Given this list of marker genes MAPK3, SP100, FCGR1BP, NUP42, FANCF, IKBKB, FAAP24, HSPA1B, TUBA1B, TUBB2B, PDE12, EIF4E2, TRIM21, SOCS3, FANCM, ILF3, EIF4A2, NUP155, TRIM29, HLA-DQA1, NCK1, GBP4, TUBA1C, JAK1, EIF4G1, MAVS, SPHK1, HLA-DQB2, FNTA, BECN1, TRIM5, TRIM17, IFIT5, TUBA4B, TRIM68, DUS2, CIITA, HLA-G, RAF1, NUP35, AAAS, RPS27A, EIF2S1, MT2A, IFNB1 (interferon beta 1), FANCL, POM121, RSAD2, NUP50, HLA-DQB1, HLA-DRB1, PTPN1, YBX1, SAMHD1, TUBB1, NUP133, ADAR, VTRNA2-1, IRF1, HLA-DQA2, EIF2S2, TRIM8 (tripartite motif containing 8), DHX9, IFNA8, NUP93, IFNGR2, PTAFR, IFNA4, GBP5, GBP2, EIF4G3, PLCG1, HLA-A (major histocompatibility complex, class I, A), PTPN6, UBE2L6, UBA52, UBC (NCBI Gene Id 7316), OAS2, IFNG, NUP188, VCAM1, FCGR1A, PTPN2, tat, EIF2S3, HLA-DPA1, FLNB, TUBB8B, RANBP2, IFIT3, FANCA, HLA-DRB3, TUBA3C, CHUK, STAT2, NUP62, TUBA1A, KPNA1, IFI6, NUP153, PSMB8, RIGI, MX2, TRIM45, OASL, CAMK2D, ATF6, ACTG1, MID1, IFIT2, NUP37, EIF4E, HSPA2, BST2, SMAD7 (NCBI Gene Id 4092), CASP1, NPM1, OAS1, IP6K2, HSPA1A, IFNA1, NUP210, TRIM34, TP53, FANCG, CAMK2G, KPNA2, HSPA8, ACTB, SOCS1, IFNA14, IFNGR1, CENPS, ABCE1, PRKCD, MAPT, UBE2I, KPNB1, TRS1, SUMO1, IFITM2, TUBAL3, NUP205, TUBB4B (NCBI Gene Id 10383), NUP54, TUBB6 (tubulin beta 6 class V), HLA-E (major histocompatibility complex, class I, E), TUBA8, PPP2CA, DNAJC3, IRF5, ILF2, NEDD4, TUBB2A, TRIM26 (NCBI Gene Id 7726), SEH1L, PGGT1B, IFNA5, PIN1, FKBP5, ISG15 (NCBI Gene Id 9636), TRIM25, IFI27, TPR, PPP2R1B, RAE1, EIF2AK3, IFI35, IFI30, EIF4G2, PIAS1, FNTB, NUP58, IRF9, NUP98, NUP85, PPP2CB, FANCE, ISG20, SFN, N, TRIM6, KPNA5, IFI44L, SEC13, NCAM1, STAT1, FCGR1B, CDK1, GBP1, EIF4A3, MAP2K6, TUBA4A, HERC5, IFNAR2, EIF4A1, FLNA, TRIM31, FANCB, TRIM35, IFNA6, CAMK2B, UBE2N (ubiquitin conjugating enzyme E2 N), FAAP20, NUP88, TUBB3, IFIT1 (interferon induced protein with tetratricopeptide repeats 1), FAAP100, HLA-DPB1, OAS3, SNCA, TRIM38, TUBA3D, HSPA1L, UBE2E1, XAF1, TRIM46, USP18, Human respiratory syncytial virus A2, complete genome, HLA-B, PML (PML nuclear body scaffold), KPNA3, RNASEL, TRIM62, HLA-DRB5, PPP2R1A, JAK2, IFITM1, IRF6, NUP107, CD44, PTPN11, EGR1, MAPK1, IFNA10, TRIM14 (tripartite motif containing 14), IFI44 (NCBI Gene Id 10561), IFNA7, HLA-DRA, TARBP2, TUBB8, NUP214, FURIN, PRKRA, EIF4E3, TUBA3E, NS, PPP2R5A, TRIM22, TUBB4A, UBB, IFNAR1, UBA7, TRIM10, TYK2, MX1, IFITM3, IFIH1, STAT3, HSPA5, IRF4, ICAM1, IRF8, GBP7, IFNA16, HLA-H, IFNA17, KPNA7, HLA-F, KPNA4, NUP160, GBP6, PIM1 (Pim-1 proto-oncogene, serine/threonine kinase), POM121C, IFNA21, gag, HLA-DRB4, VP3, CENPX, IRF3, IRF7, TRIM3, EIF2AK2, IRF2, FANCC, TRIM48, PPM1B, ARIH1, CAMK2A, NUP43, GBP3, TRIM2, IKBKG, HLA-C, NDC1, B2M, IFNA2, here is a description of the gene set: Reactome Pathway: Interferon Signaling part of: Cytokine Signaling in Immune system species: Homo sapiens Interferons (IFNs) are cytokines that play a central role in initiating immune responses, especially antiviral and antitumor effects. There are three types of IFNs:Type I (IFN-alpha, -beta and others, such as omega, epsilon, and kappa), Type II (IFN-gamma) and Type III (IFN-lamda). In this module we are mainly focusing on type I IFNs alpha and beta and type II IFN-gamma. Both type I and type II IFNs exert their actions through cognate receptor complexes, IFNAR and IFNGR respectively, present on cell surface membranes. Type I IFNs are broadly expressed heterodimeric receptors composed of the IFNAR1 and IFNAR2 subunits, while the type II IFN receptor consists of IFNGR1 and IFNGR2. Type III interferon lambda has three members: lamda1 (IL-29), lambda2 (IL-28A), and lambda3 (IL-28B) respectively. IFN-lambda signaling is initiated through unique heterodimeric receptor composed of IFN-LR1/IF-28Ralpha and IL10R2 chains. <br>Type I IFNs typically recruit JAK1 and TYK2 proteins to transduce their signals to STAT1 and 2; in combination with IRF9 (IFN-regulatory factor 9), these proteins form the heterotrimeric complex ISGF3. In nucleus ISGF3 binds to IFN-stimulated response elements (ISRE) to promote gene induction. <br>Type II IFNs in turn rely upon the activation of JAKs 1 and 2 and STAT1. Once activated, STAT1 dimerizes to form the transcriptional regulator GAF (IFNG activated factor) and this binds to the IFNG activated sequence (GAS) elements and initiate the transcription of IFNG-responsive genes. <br>Like type I IFNs, IFN-lambda recruits TYK2 and JAK1 kinases and then promote the phosphorylation of STAT1/2, and induce the ISRE3 complex formation.